The following is a description of a gene set: Human Gene Set: HP_CONSTIPATION species: Homo sapiens Constipation Infrequent or difficult evacuation of feces., and this is the list of marker genes: GDNF, SLC6A8, TGFBR2, NGF, OPA1, UBE3A, ELF4, USP7, ASH1L, SPTBN1, PRKN, TPO, MED12, STAG2, RPS20, WDR26, CNBP, DES, SMPD1, DUOXA2, TNFRSF1A, SIN3A, MRPS34, NKX2-5, PPOX, GJC2, TGIF1, ECE1, ZNF292, FRMD5, MT-TT, TG, MT-ND6, PWAR1, TBP, CTSH, EIF4G1, LMNB1, AVPR2, COL7A1, SLC26A4, STAR, FKBP6, TWNK, ARSB, NFIX, TNFSF4, MLH1, PIGS, HMBS, FGF12, UPF3B, ALPL (alkaline phosphatase, biomineralization associated), FOXP1, ERBB3, LUZP1, NAB2, KCNJ1, SOX10, TBCD, MAPT, OTX2 (orthodenticle homeobox 2), PRNP (prion protein (Kanno blood group)), HSPG2, ALDOB, MT-TW (NCBI Gene Id 4578), GABRA3, UCHL1, NRTN, CDKL5 (cyclin dependent kinase like 5), ATM, SPART, DPF2, TRH, H1-4, SEC61A1 (SEC61 translocon subunit alpha 1), SCN11A, FLII, MYO1H, GTF2IRD1, CACNA1S, SIX3, EP300, TFE3, CAMTA1, ZMIZ1 (NCBI Gene Id 57178), ZFX, POLE, FLI1, CAMK2B, EIF4H, PRDM16, FOXG1, TRIM8, LAMC2, ADAT3, UGP2, USP9X, YME1L1, KCNJ18, MBD5 (NCBI Gene Id 55777), CDKN2C, MSH6, IQSEC2, LHX3, VANGL1, PDPN, OTUD6B, MALT1, OCRL, PODXL, HTRA2, P2RY11, BMPR1A, PPP1R21, CASR, TSPOAP1, NODAL, UFC1, STIL, FGF8, TAF1, TAF4, VPS35, MED13, SLC6A3, CACNA1C (NCBI Gene Id 775), H4C5, SDHA, ZEB2, CLP1, CHEK2 (checkpoint kinase 2), RFC2, FOXH1, GTF2IRD2, HS2ST1, CDON, SLC38A3, VPS37D, B2M, WAC, DUOX2, TSHB, GRIN1, PMS2, FAR1, SKI, RMRP, PTCH1, FBXO11, DNAJC6, SETD1A, PLA2G6, LRIG2, POR, NAA80, PEX16, KCNAB2, NPAP1, MT-TF, NNT, LAMA3, HIVEP2, SOX17, CISD2, ATN1, ATP1A3, SNRPN, COL5A1, HLA-DRB1, STAT3, NALCN, SYNJ1, CREBBP, SCNN1A, UBE4B, SATB1, APC2, MAGEL2, GLI2, SMO, HCRT, PACS1, BRAF, DNM1, COL5A2, LMNB2, LIG4, NSD2, EDNRB, POLG2, IGHMBP2 (NCBI Gene Id 50985), ATXN2, EPCAM, MUTYH, HEXB, SEMA3D, BUD23, TYMP, DLL1, DYRK1A, PPP1CB, SNCA, SNORD116-1, SLC5A5, ATXN8OS, PCGF2, AFG2A, LMX1B (LIM homeobox transcription factor 1 beta), P4HTM (NCBI Gene Id 54681), KMT5B, NKX2-1, RET, AFF4, ATRX, GTF2I, RORA, KDM1A, TRIO, SH2B1, LBX1, TBX1, CSNK2A1, KRAS, PRKCZ, SPEN, ADH1C (NCBI Gene Id 126), RERE (arginine-glutamic acid dipeptide repeats), CACNA1A, CHCHD2 (NCBI Gene Id 92547), SLC1A3, DMPK, SHQ1, MT-TQ, CHD8, TTR, HNRNPK, CTNS, SRCAP, HNRNPH2, SPOP, OCA2, UBE3B, DEAF1, CLCNKB, CHMP1A (NCBI Gene Id 5642), EIF4A2, VPS13C, GRIA1, CDK13, BRCA1 (BRCA1 DNA repair associated), SLC9A6, PAX8, GNB2, POLD1, BIRC3, CAVIN1, STX1A, PPM1D, GBA1, NGLY1, PAK2, ATP7A, MT-TL1, TCF20 (transcription factor 20), CDC73, SNORD115-1, TCEAL1, DHCR7, SLC12A1, MKRN3, ELP1, CUBN, RFX7, IGBP1, PIGV, SMARCA2, DNAJC30, HERC2, ADNP, EXT2, FBXO28, SETD5, PHOX2B, TBL1X, HIRA, MT-CO1, ZNF365, DHPS, MOGS, THRA, ABCD1, HESX1, CDKN1B, SLC25A4, DDC, KMT2B, DISP1, SLC12A2, TH, SI (sucrase-isomaltase), PDGFRA, MT-CO2, TCF4, HLA-DQB1, CASZ1, BICRA, IPO8, SDHB, MOG, PROKR2 (NCBI Gene Id 3733), PARK7, ACTG2, DSE, MSH2, SLC12A3, MNX1, RAI1, HPSE2, SCN9A, BCL10, ASCC3, COQ2, PMS1, ZMYM3, UBE2A, APC, NCF1, COMT, ERBB2, AQP2, SALL1, PLCB4, POGZ, POLRMT, ZIC2, BAZ1B, MT-CO3, SNCAIP, EHMT1 (euchromatic histone lysine methyltransferase 1), CD96, PPP2R1A, MLXIPL, FOXA2, ODC1, PRKG2, ATXN3, WFS1, TMEM270, FGFR1, STAT6 (signal transducer and activator of transcription 6), CNP, ABL1, GGT1, MT-ND4, NR4A2, GP1BB, LAMB3, KMT2A, PWRN1, CNTNAP2, PSMB8, ZSWIM6, BRCA2, WASF1, GRB10, AFF3, LHX4, SMC1A, SREBF1, MT-ND5, MEN1, FLNA, SDHC, PHIP, SLC25A36, MRAP, SOX2, POLG, MLYCD, MT-TS2, MYH11, POU1F1, COL1A1, CTCF, PCCA, UFD1 (ubiquitin recognition factor in ER associated degradation 1, NCBI Gene Id 7353), NSD1, GALNT2, ARNT2, TSHR, GATAD2B, MMP23B, TANC2, RNU4-2, PINK1, SCNN1B, SCNN1G, MARS2, VPS11, DDHD2, STXBP1 (syntaxin binding protein 1), NRXN1, ARVCF, H3-3A, DACT1, ARID2, ALAD, METTL27, LIMK1, MC2R, MEFV, MPV17, H3-3B, SEC24C, KIT, MED12L, SEMA3C, AMN, SCN10A, DNAJC13, VPS51, MT-ND1, TAOK1 (TAO kinase 1), TLK2, SHH, DCPS (decapping enzyme, scavenger), SLC32A1, RREB1, SEMA4A, KCNH1, CHRM3, TBL2, NSUN2, GIGYF2, FDFT1, MSL3, CRIPTO, EDA, DDOST, PIK3CA, MDH2, CHST14, CDKN2B, TMCO1, SUPT16H, MECP2, TXNRD2, MT-TH, POU4F1, ELN, EIF5A, FBXW7, LRRK2, CDKN1A, PLCH1, MITF, FGF13, GAS1, FOXE1, AHDC1, EDN3, UNC80, PCCB, IYD (NCBI Gene Id 389434), GABRD, MED25, ATP1A2, SOX3, CLIP2, RRM2B, CPOX, JMJD1C, MADD, PROP1, SIK3